Given this list of marker genes ADGRE1, TNFSF10, AKR1C2, ZBTB26, MRPS33, STEAP1B, RMND5B, CASP10, SLC20A1, MAP2K6, MTG2, CDC42BPG, MMP28, KCNK15-AS1, TMCC2, MTHFD2L, NSMCE1, PHB1, LSM3, IFTAP, YBX3, GIMAP5, BAIAP2-DT, UBIAD1, AIF1, NMNAT3, MTRFR, EDAR, UTP14C (NCBI Gene Id 9724), CAND2, RPS9, MSX2, MIF, EPHX2, CHPF2, FLOT1, GSAP, ASB13 (NCBI Gene Id 79754), LYRM9, MTARC2, CACNG8, TANC2, CDC14A, PRRT1, LIG1, IFITM2, IL17RE, SNORD104, ANKRD10, SULT1B1, SNTG1, IMMP1L, GIGYF1, TSEN2, NUFIP1, SGSM3, SNORC, LRP6 (NCBI Gene Id 4040), INPP4A, TRIM2 (NCBI Gene Id 23321), MAN1C1, MARCHF10, IGF1R, NDUFAF8, PAXIP1-AS2, TMOD2, ZNF529, PRXL2A, NDRG2, KIF9, YAE1, DECR2, RBM20, SERTAD2, MRPL55, TFPT, NIN, AOAH, TPM2, PLAC8, TIMM9, DNMT3A, EXOSC8, AKR1B1, ZFAND4, TTC9, SPACA4, STK26, NBPF4, BCAS4 (breast carcinoma amplified sequence 4), KISS1R, MRPS22, RPS14 (NCBI Gene Id 6208), OXNAD1, RPL4, SPACA9, RPL22, ZNF609, TRPC4, NELL2, RGL4, C1orf116, RPL6, GAPVD1, BAG3, PLEKHB1, SSBP3-AS1, TESPA1, CCL2, DHX35, CEPT1, FASTKD2, DIP2C, SDR39U1, CLPS, MTRF1, SLC25A23, FBXL4, ST6GALNAC1, PMFBP1, CHCHD10, SVIL, REX1BD, ACSL6, CCDC57, RPS5, FAM223A, ANKRD50, TNPO2, TMEM229B (NCBI Gene Id 161145), ADGRL1, LEF1-AS1, MAL, S100B, ARHGDIG, TPCN1, AKR1C1, CDK5RAP1, AMT, CBX6, BACH2, ZNF280B, UBTF, HOOK2, PLAG1, NDUFS4, PTPRK, CAD, SIAH3, FAM171A1, LIPT2-AS1, PDCD4-AS1, CCT7, CTDSP2, MYADM, BTBD3, KCTD3, SYPL1, RIN3, APP, GIMAP8, EPPK1, NEPRO, MOV10, PIK3CD, TMEM131L, MGC16275, NUDT9, GTPBP8, RPL13A, ATP5PF, PAN2, TM2D3, AARS2, PAGR1, ZC3H12B, SPIN1, PIGR, HYI (hydroxypyruvate isomerase (putative)), PDIA5, ZDHHC4, PPP1R13L, PRMT5, CCS, CARMIL1, ZNF667-AS1, VGLL4, HIPK2, GPR146, AK5, PPP1R3E, IFITM3, BNIPL, SCARA5, CCDC112 (coiled-coil domain containing 112), here is a description of the gene set: studied in species Homo sapiens Genes down-regulated in comparison of adult regulatory T cell (Treg) versus adult conventional T cells. Human Gene Set: GSE25087_TREG_VS_TCONV_ADULT_DN We compared differences in fetal and adult T cells by performing whole genome profiling on sort-purified T cells (naïve CD4+ and Treg cells) from human fetal specimens (18-22 gestational weeks) and adult specimens (age 25-40 years old). Fetal and Adult Naïve CD4+ T cells phenotype: CD3+CD4+CD45RA+CCR7+CD27+, Fetal and Adult CD4+CD25+ Treg phenotype: CD3+CD4+CD25bright from publication Mold JE, Venkatasubrahmanyam S, Burt TD, Michaëlsson J, Rivera JM, Galkina SA, Weinberg K, Stoddart CA, McCune JM (PMID 21164017)